Given this list of marker genes POMGNT1, SMS, AP4E1, MASP1 (NCBI Gene Id 5648), ARNT2, SIX3, HRAS, DDX3X, PTPN14, PTCH1, ALG3, GLI3, LOX (lysyl oxidase), ALG14, VAC14 (VAC14 component of PIKFYVE complex), PCLO, SMARCA2, SMC5, FLNA, SNX14, HMGA2, COL6A1, NAA10, IL17RD, CACNA1S, MRPL12, KIF7, KIF15, PIGO, PIGA, PEX14, ACTA1, ZDHHC9 (NCBI Gene Id 93950), RPL18, SHOX, B4GALT7, SMO, HES7, LIG4 (NCBI Gene Id 3981), POMGNT2, PRUNE1, NLRP3, PIGU, DONSON, CNTNAP2, HECTD4, DBH, HESX1, HBA2, RPGRIP1L, SPRED2 (sprouty related EVH1 domain containing 2), NDUFB11, NIPA1, KIAA0753, ATP6V1B2, DUSP6, GATA3, KMT2A, WDPCP, AP4S1, PHIP, FBXL3, KIF21A, TMEM237, OFD1, COL11A1, CFAP418, RUSC2 (NCBI Gene Id 9853), COL2A1, GATA1, RB1, CHRNE, ACTA2, FIG4 (NCBI Gene Id 9896), RPS29, DAG1 (NCBI Gene Id 1605), SF3B2, IFT74, GDF6, COL4A1, VAMP1, EXOC7, DPH2, TBX2, BRD4, RAB34, PGAP2, SETBP1, STIL, CILK1, TRRAP, SCLT1, PDE11A, ARMC9, CHD6, TCF3, DLX5, RPS23, SCO2 (synthesis of cytochrome C oxidase 2), MTX2, GTF2E2, USP9X, GRIN1, SMCHD1, FEZF1, MYLK, GLI2, COG5, KPTN, MBTPS2, CPLX1, NONO, PCDHGC4, ABL1, OSGEP, HPDL, ATG7, FANCA, SCARF2, C2CD3, COLEC10, BRCA1 (NCBI Gene Id 672), RARB, CTU2, FUT8, FANCM, KDM6B, TBC1D20, NCDN, KCTD1, GRM7, ADARB1, PDZD8, POLR3A, WNT5A, GREB1L, TBCK, PITX1, MFAP5, MRAS, CDON, PPP1CB, SLC35D1, FANCI, ARX, RREB1, ALDH6A1, CDH11, KIFBP, YARS2, SH3BP2, CD79A, LAGE3, BBS1, EDEM3, MED13L, BBS7, RPL27, EEF1A2 (NCBI Gene Id 6669), BUB3, ZFX, CTNND2, EP300, MEOX1, HYLS1, ESS2, MT-CYB, PRKAR1B, CDH2, NAE1, CBS, ANAPC7, PIGP, SLC39A13, RARS2, WDR4, ZNF699, SLF2, RFWD3, INTS1, IGF2, MED25, ATR, GJB2, SLC5A7, POLA1, DHX30, ATP6V1E1, PIK3R1, NEK1, SCN4A, FGF9, NSD1, LARS2, TBL1XR1, GBA1, GFRA1, MAT2A, CACNA2D1, SLC25A46, HNRNPH1, AP4M1, ANKRD11, BRAT1, SMAD3, SELENOI, FTO, SMC3, RAB3GAP1, PLAG1, SETD5, TMCO1, RMRP (RNA component of mitochondrial RNA processing endoribonuclease), PQBP1, GTF2H5, SLC35B2, SKI, PAX7, ASXL1, ALG2, PSAT1, JARID2, REEP1 (receptor accessory protein 1), EIF2S3, PRDM5, BBS9, SEMA5A, SOX5, QRICH1, HUWE1, TAC3, ORC4, RPL9, PGAP1, EIF4A3, HS6ST1, H4C5, SERPING1, HSD17B4, ECM1, SOX2, SOX9, ORC6, RFX7, ADAT3, ARHGEF38, ABCC6, SLC35A2, PRKAR1A, HYMAI, DPYSL5, PUM1, TAOK1, PALB2, ADSS1, RPL8, PAX1, SEC31A, LFNG, RTL1, NIPBL, UFC1, POLR2A, KLHL7, DDX11, RAPSN, POU1F1, HS2ST1, KLHL41, SPEN, KIAA0586, RYR3, TUBA1A, PPP3CA, FGF20 (fibroblast growth factor 20), DPM1, METTL23, SPTBN1, POMT2, MAP3K20, RBM10, NHLH2, SCUBE3, COL5A1, ALG9, MECOM, TBX1, BAP1, PDHX, TOGARAM1, EARS2, SPEG, KBTBD13, SPTBN4, PLAGL1, MT-TN, RPL11, AK9, KRAS, PRRX1, EIF2AK3, DGCR8, TGDS, TBX4, ATRX, PROK2 (prokineticin 2), CHKA, TNNI2, DHCR24, AMER1, MYMK, DSE, RAB3GAP2, RYR1, HNRNPH2, SNAP25, ERCC2, RAP1B, PIGL, FRA10AC1, RPL15, CTNNB1, PEX26, BCOR, SLC25A1 (NCBI Gene Id 6576), IRX5 (iroquois homeobox 5), LAMB2, PEX2, CPT2, KAT6A, FLI1, SEC24C, NF1, ACBD5, RIPK4, SIN3A, PUS7, UBB, CNTN1, PUF60, TRIO, PGAP3, PIGG, ERF (NCBI Gene Id 2077), UBA1, RRAS, BIN1, OCLN, PRR12, SOX10, MSTO1, PEX6, LEMD3, SLC35C1, CCDC28B, HOXB1, MT-TE, GNAI3, KMT2D, HCCS, PEX5, EPG5, CEP152, AFG2B, CRIPTO, KIF14, RAB23, MAF, THSD4, PYROXD1, STAG1, RLIM, SPOP, MYMX, CAMSAP1, SYNGAP1, KAT6B, TRIP4, TRIM8, HECW2, NFIX, SMAD4, NELFA, KISS1R, LHX4, CEP290, CLP1, WBP4, FOXL2, GEMIN4, SEC23A, RIPPLY2, PHGDH, RPS20, ASXL3, PEX7, ADAMTS10, SHMT2, NEFL, FBN2, PGM2L1, TRIP13 (thyroid hormone receptor interactor 13), SRY, CC2D2A, TIMM50, ATP6V1A, TUBG1, ROR2, DPH5, CHD7, TBCE, MAD2L2, KCNJ2 (NCBI Gene Id 3759), TCTN3, APC2, RIN2, CDH1, CRELD1 (NCBI Gene Id 78987), IGHM, NUP107, PNKP, TAPT1, AP4B1, PEX3, BMPR1A, CDC6, SEMA3A, ARID1B, TMEM231, DLG1, HDAC9, RERE, TRPV4, LETM1, MKS1, FOXE1, MAPKAPK5, FZD2, PIGW, HOXA2, CHAMP1, COL12A1, GRHL3, RPS28, KCNJ6, FLCN, COL1A2, COL6A2, H19, DST, GSC, G6PC3, ITGA7, DVL1 (dishevelled segment polarity protein 1), THOC6, MAP3K7, RNU4ATAC, INPPL1, FGFR3, VPS51, COL9A1, LRP4, PMM2, FH, RRM2B, NXN, BUB1 (NCBI Gene Id 699), SOX3, SLC26A2, BBS2, COL3A1, CREBBP, XYLT1, TET3, ANK1, ASCC3, TCTN1, ZNHIT3, SET, TELO2, CHUK, ACTN2, B3GLCT, ADNP, LTBP1, TGFB2 (NCBI Gene Id 7042), AHI1, ARL6, CDC45, GNPAT (glyceronephosphate O-acyltransferase), KCNK9, ELMO2, GNB1, FBXO28, FBN1, MYH2, TLK2, CCBE1, ITPR1, KMT2C, TARS1, MYL11, OTUD6B (NCBI Gene Id 51633), ASPM, DYNC2H1, YWHAE, FRAS1, CDK10, CNTNAP1, SLC18A3, INTS11, THOC2, PIGN, WARS2, SIX1, DHCR7, NIPA2, AKT1, FANCE, MAPK1, ZBTB20, TAF6, SIX5, YAP1, TWIST2, EBP, GNRH1, TAF4, CHRNA1, SHH, FBXO11, ANKRD17, LMOD3, B9D1, MYL2, COL9A3, TECR, HEATR3, FREM2, NALCN (NCBI Gene Id 93074), DLK1, PEX1, NUAK2, STAG2, NR2F1, ACBD6, PLOD1, PAX3, BICRA, ZBTB24, MAPRE2 (microtubule associated protein RP/EB family member 2), MYOD1, WNT9B, PIGB (NCBI Gene Id 9488), COMT, POLR1A, KIF26A, MAP2K1, COX6A2, ANO1, NOTCH2, SH3PXD2B, RPS10, DPH1, LMBRD1, SLC39A7, B3GALNT2, MYO9A, GRIA3, RPS7, MINPP1, DIS3L2, HBA1, IGLL1, CARS1, WDR11, CEP41, SELENON, WDR35, ALX4, DVL3, GDF11, MAFB, NUP188, RPS26, FGD1, LBR, TUBB, HNRNPK, SLC17A5, SDHD, B3GAT3, SEC23B, CHST14, BGN, ERI1, FGFR1, FOXI3 (forkhead box I3), EDNRA, MAPK8IP3, FARSB (NCBI Gene Id 112957), TTN (NCBI Gene Id 7847), ODC1, HACD1, PYCR1, MED12, NDNF, CHRNB1, HSPA9, CTBP1, NR4A2, BBS10, MID1, TBR1, SDHC, ZMPSTE24, ARVCF, KLLN (NCBI Gene Id 100144748), FOXC2, GRIP1, XRCC2, PEX13, ASH1L, OBSL1, SC5D, MYO18B, COPB1, RAB18, IER3IP1, TCTN2, LRRC8A, TMEM216, GIPC1, CA2, CDT1, CHAT, ERLIN2, SNRPN, ZPR1 (NCBI Gene Id 95155), KAT5, HPGD, VPS13B, WLS, RPS6KA3, GNAO1, POR, CHD3, SDHB (succinate dehydrogenase complex iron sulfur subunit B), AHDC1, PEX10, SH2B1, SLC6A17, BPNT2, DLG5, PEX12, FLII, CHST3, PAK3, NSUN2, AR, CEP19, LARGE1 (LARGE xylosyl- and glucuronyltransferase 1), NAA60, WNT4, PGM1, TBC1D24 (TBC1 domain family member 24), INPP5E, FANCG (FA complementation group G), WNT7A, GPC3, IQSEC2, RUNX2, IL11RA, PRPS1, CNOT1, PRKG1, POGZ, ORC1, PDE6D, MECP2, SCNM1, SLC25A19, IFT27, PI4KA, GNRHR, ALX3, SEC24D, ATN1, EFNB1, YARS1, SPTAN1, IRF6, AGRN, NEK9, ECEL1, RBM8A, TFAP2A, SLX4, FLNB, EFEMP1, TBX6, TBX15, MPLKIP, SMOC1, FOXF1, PROKR2, DPAGT1, DLG3, PIGT, DYRK1A, SHOC2, SPRED1, GABRA3, SLC12A6, MOGS, DEAF1, MEGF8, USF3, RPL35A, ATP7A, TUBB6, RPGRIP1, SUPT16H, AASS, CBL, DISP1, MCTP2, ESAM, DCHS1, AEBP1, DEF6, MESP2, KDM5C, CCN2, TCF4, MAGEL2, ELN, RET, TBX5, KDM6A, CTNND1, NKX6-2, AIFM1, JUP, L1CAM, HYAL1, KCNJ5, GMPPB, CDK19, SCN2A (NCBI Gene Id 94312), KCNA1, ERCC5, ARHGAP31, SOS1 (NCBI Gene Id 7838), CEP57, FAM20C, SNIP1, CPLANE1, GPC4, SATB2, COLQ, NSRP1, SALL4, TNNT1, TTC8, ERCC4, UBAP2L, TGIF1, DHPS, IFT172, CPSF3, SF3B4, LGI4, SURF1, TPM3, NUP88, LTBP2, DLL1, KANSL1, RPS17, SDCCAG8, TRAPPC2, SON, KCNH1, SIX2, EXT1, RNASEH1, CLCF1, SOX11, MYL1, FGF8, NDUFAF6, TWIST1, MEGF10, SMPD4, LRP12, DGCR2, ARCN1, NOTCH3, RAD51, SLC25A24, EXOSC9, GATA4, FGF17, PIGQ, LMX1B, ARHGAP29, RAF1, GATAD2B (GATA zinc finger domain containing 2B), ACTB, MSX2, GP1BB, AP1S2, DDHD2, PROP1, MYH11, INTU, TBX22, MYBPC1, DDX59, RPL5, SMC1A, ERCC3, PEX11B, RXYLT1, LRP5, WDR73, MUSK, NSD2, SUMO1, PIK3CA, GRB10, FN1, BRCA2, PTEN, FRMPD4, SMARCD1, IL6ST, SMARCA4, SIK1, PTPN11, UBE3B, SOS2, ZNF668, RPL26, TUBB3, CHRNG, EBF3, DDX6, FOXA2, NSDHL, WASHC5, MYH3, HERC1, SMARCB1, MAMLD1, DDR2, TGFBR2, ATP6V0A2, DHODH, MEIS2, GJA8, POMK, HNRNPU, HAAO, ZSWIM6, COG1, CYP26C1, PGM3, PLCB4, SLC32A1, LRRC32, IFT122, ESCO2, COBLL1, BMP2, PRMT7, MKKS, CUL4B, RAD21, RPL31, TRMU, MYH7, GPT2, FOXH1, FGF10, RPS15A, PLCH1, OCRL, PIGV, NOTCH2NLC, NBN, POMT1, EFEMP2, MARS1, TNNT3, ENG, QARS1, VAX1, FANCB, PORCN, COL9A2, CRPPA, TRPM3, EFL1, RAI1, SLC25A22, ASPH, FGFRL1, CEP295, RRAS2, TACR3, COL6A3, FANCC, ADA2, SPECC1L, ATP9A, TRIP12, JMJD1C, NECTIN1 (nectin cell adhesion molecule 1), HEY2, RNU4-2, POLR1C, CHSY1, PIGH, PPP2CA, SUFU, NEDD4L, TXNL4A, TGFBR1, CDKL5, COL11A2, CRLF1 (NCBI Gene Id 9244), SCAF4, SNRPB, PURA, FGFR2, SYT2, TSPEAR, CHRND, EYA1, KCNN3, BBIP1, TMEM67, GMNN, PAH, GJA5, SEMA3E, MAP1B, NODAL, KDM1A, TWNK (twinkle mtDNA helicase), HYOU1, KISS1, ZC4H2, PIEZO2, AFF4, POLRMT, MAP2K2 (mitogen-activated protein kinase kinase 2), GJA1, PYCR2, MCM3AP, COX14, LMNA, NSMF, CD79B, SIK3, RIC1, SCAPER, DCC, RNU12, SCN1B, SOX6, RPS27, BBS4, TXNDC15, SPINT2, CCDC141, BRIP1 (NCBI Gene Id 83991), DGCR6, CRKL, ZMYM2, GNE, RPL35, HOXD13, SLC2A10, ITGA8, ACTG2, PDGFRA, FANCL, CD96, KATNIP, GFPT1, SMG9, IGBP1, NDUFA8, INSR, COX7B, COL13A1 (collagen type XIII alpha 1 chain), OTX2, HIVEP2, DSP, SPRY4, POLR1B, TASP1, RSPO2 (R-spondin 2), COLEC11, DOK7, RILPL1, UBE2T, CAMTA1, WDR26, TSR2, PEX19, WBP11, FLRT3, ADAM22, BUB1B, NRCAM, CFL2, BCR, CHD4, CENPF, ZNF469, ALX1, RECQL4, NFASC, RAD51C, ZEB2, BBS12, GLE1, DMXL2, PIGY (phosphatidylinositol glycan anchor biosynthesis class Y), CCDC22, NEUROD2, FKBP14, YY1, RIT1, DPYD, FANCF, MEG3, UFD1, EIF5A, SHANK3, ADAMTS15, FAM50A, KMT2B, FKTN, GDF3, TGFB3, B3GALT6, IGF1R, SMAD2, EFTUD2, CTCF, ACVRL1, NEUROG1, APC, PCGF2, NRAS, MYCN, MAN2C1, IFT140, RASA2, CLCN3, HSPG2, GAD1, PLXND1, CHN1, ARID1A (NCBI Gene Id 8289), FKRP, RPS24, LZTR1, DLL3, UPF3B, TFE3, SLC25A12, WNT3, CSPP1, FOXE3, TP63, FANCD2, BMPER, MSX1, KDF1, ANTXR1, STAC3, TRIM32, MYPN, AP1G1, PHF8, TMEM107, SP7, PPP2R5D, FAM149B1, DOCK3, TTC5, TOPORS, PAFAH1B1, TAF1, ATAD1, MED12L, B9D2, PUS1 (pseudouridine synthase 1), MN1, CDKN1C, HERC2, CLTC, AARS1, NPHP1, STAT3, TPM2, SKIC3, CEP120, CUL3, AMMECR1, CASK (NCBI Gene Id 8573), SIAH1, CTSK, FOXP2, ZNF292, ARID2, VPS35L, BRAF, ANOS1, MTM1, MADD, BLTP1, EDN1 (endothelin 1), SEPTIN9, ZIC2, RPS19, DPM2, SLC10A7, PPP1R21, NEB, STAMBP, TOE1, DLX4, REV3L, ARHGEF2, B4GAT1, BBS5, GAS1, IPO8, CCDC47 (NCBI Gene Id 57003), IBA57, TRPS1, ERMARD, RNF113A, MESD, FILIP1, FAT4, LZTFL1, PTDSS1, BMP4, PEX16, TCOF1, POLR1D, HDAC8, PLAA (NCBI Gene Id 9373), CSNK2A1, FLVCR2, BLNK, ZNF341, GNB2, HIRA, PEPD, SPI1, CCDC32, here is a description of the gene set: Any abnormality of the palate, i.e., of roof of the mouth. Human Gene Set: HP_ABNORMAL_PALATE_MORPHOLOGY studied in species Homo sapiens Abnormal palate morphology